The following is a description of a gene set: Human Gene Set: GOBP_POSITIVE_REGULATION_OF_GRANULOCYTE_CHEMOTAXIS Any process that increases the rate, frequency or extent of granulocyte chemotaxis. Granulocyte chemotaxis is the movement of a granulocyte in response to an external stimulus. species: Homo sapiens, and this is the list of marker genes: DAPK2, RIPOR2, XCL1, THBS4, CCL21, PERP, DNM1L, MCU, NCKAP1L, LBP, RAC1, CCR7, C5AR1, IL23A, TIRAP, CXCL8, CAMK1D, C3AR1, RAC2, S100A14, S100A7, EDN1, MOSPD2, CD74, C1QBP, MDK, CCL19